The following is a description of a gene set: Genes encoding collagen proteins One hallmark of ECM proteins is their domain-based structure. Exploiting this characteristic, we established a list of diagnostic InterPro domains commonly found in ECM proteins. We know that some of the domains used to select positively for ECM proteins are also found in transmembrane receptors and proteins involved in cell adhesion (growth factor receptors, integrins, etc) that do not belong to the ECM. These families of proteins also display a subset of specific domains and transmembrane domains incompatible with definition as studied in species Mus musculus from publication Naba A, Clauser KR, Hoersch S, Liu H, Carr SA, Hynes RO (PMID 22159717) Mouse Gene Set: NABA_COLLAGENS, and this is the list of marker genes: Col9a1, Col4a4, Col8a1, Col15a1, Col3a1, Col24a1, Col4a6, Col5a1, Col4a5, Col6a3, Col4a1, Col22a1, Col28a1, Col19a1, Col1a1, Col11a2, Col4a3, Col18a1, Col5a2, Col6a5 (collagen, type VI, alpha 5), Col4a2, Col14a1, Col16a1, Col6a1, Col9a2, Col11a1, Col1a2, Col9a3, Col12a1, Col27a1, Col13a1, Col6a4 (collagen, type VI, alpha 4), Col10a1, Col17a1, Col6a2, Col26a1, Col8a2, Col7a1, Col25a1, Col2a1, Col20a1, Col5a3, Col23a1, Col6a6